Given this list of marker genes Ppara (NCBI Gene Id 399624), Acvr2a, Cd34, Bcl11b, Dlx2, Fam20c, Tnfrsf11b, Smpd3, Apcdd1, Acvr2b, Dmrt3, Foxc1, Perp, Enpp1, Tmt1a3, Bmp4, Ankrd11 (NCBI Gene Id 78664), Id3, Apc, Src (NCBI Gene Id 99351), Pitx2, Osr1, Bmpr1a, Hdac2, Inhba, Tcf7l2, Adm, Csf3r, Wnt6, Acp4, Ascl5, Fst, Sostdc1, Itgb6, Amtn, Lef1, Smo, Relt, Gli2, Tspear (thrombospondin type laminin G domain and EAR repeats), Fgfr2, Gas1, Lamb1, Lrp6, Bmp2, Hdac1, Klk4, Sp7, Slc24a4, Lhx8, Gata6, Mir875, Serpine1, Cftr, Hand2, Ssu2, Trp63, Ccdc154, Dspp, Osr2, Tfap2a, Bcor, Bax, Sp6, Runx2, Tgfb1 (NCBI Gene Id 21803), Edn1, Odam, Dicer1, Snx10, Nkx2-3 (NCBI Gene Id 18089), Itga6, Tbx1, Alpl, Rogdi, Fgf4, Dll1, Traf6, Edaradd, Lama5, Slc4a2, Prkcb, Aqp1, Wdr72, Muc19, Bmp7, Tnfsf11, Odaph, Ednra, Fam20a, Enam, Aqp5, Pax9, Pdgfra (NCBI Gene Id 231312), Phex, Stim1, Lrp4, Fgfr1, Hand1, Amelx, Ift88, Edar, Ctnnb1, Aqp3, Ngfr, Wls, Tmt1a2, Tmt1a, Aspn, Eda, Klk5, Col1a1, Hacd1, Wnt10a, Nectin1, Rhoa, Myo5a, Axin2, Ctnna1, Tnc, Fgf10, Fgf8, Mmp20, Bsg, Aqp6, Msx1, Cnnm4, Dlx1, Ank, Nf2, Dmp1, Nfic, Bcl2l11, Rspo2, Chuk, Msx2, Tcirg1, Atf2, Foxo1, Jag2, Zfp422, Shh, Ambn, Ift80, Foxi3, Csf1, Gli3, Wnt7b, Dlx3, here is a description of the gene set: species: Mus musculus Mouse Gene Set: GOBP_ODONTOGENESIS The process whose specific outcome is the progression of a tooth or teeth over time, from formation to the mature structure(s). A tooth is any hard bony, calcareous, or chitinous organ found in the mouth or pharynx of an animal and used in procuring or masticating food.